The following is a description of a gene set: Genes predicted to be targets of miRBase v22 microRNA hsa-miR-5706 in miRDB v6.0 with MirTarget v4 prediction scores > 80 (high confidence targets). Human Gene Set: MIR5706 studied in species Homo sapiens from publication Chen Y, Wang X (PMID 31504780), and this is the list of marker genes: PATE4, RAD23B, GXYLT1, RBFOX1, IGF2BP3, RFC3, GCOM1, RPS6KA5, PGM2, RHAG, AZIN1, ALX4, RYR3, CXCL8, ABCC9, CTCF, ALAS1, ZCCHC7, PRRX1, WDR48, PRKG2, LHX9, CD302, RBM18, SLC2A5, TRMT11, CHL1, GYS1, MIER1, TMEM212, PTGER3, LY75-CD302, KCNAB1, ANKRD17, VTI1A, NFIB, CSPG5, PSMB4, SHISA6, CDK6, TMEM135, ZNF749, SPOP, PNPLA4, UNC5C, ALDH9A1, ADAM29, OSTC, DDAH1, CLEC19A, CHST9, STRIP1, DNMT3A, SASH1, DERL2, TMTC4, RHOQ, TMEM255A, FNBP1, NFAT5, ACER3, IFI6, HIGD1A, DCUN1D3, PCDH9, TMOD2, CAPN12, KCNMA1 (NCBI Gene Id 3778), DDI2, SAMD12, GFOD1, MAGI3, EMC7, NAA25, SOX6, CALN1, UBE2W, CRIPT, VSX1 (visual system homeobox 1), GRIA2, ARHGEF12, CNOT2, GPATCH11, HOXC10, CD28, UBXN10, CPEB2, CD164, PTGER4, FIGN, CFLAR, FAM180A, SAMD9, UNC5B, PLEKHA5, CEP44, FBXL17, TCTN1, BAZ2B, CACNA1E, MAT2B, STAG2, MIER3, CEP192, SUMO2, RNF6, CERKL, RPS6KA2, VEGFA, PAG1, TBC1D8B, ADGRE2, LYPD1, TM9SF3, GPR3, P2RX7, TSPAN33, POGZ, CCDC122, HIPK4, SMPD3, ZMAT4, PAK5, NAB1, CAST, ELOVL3, KRBOX4 (NCBI Gene Id 55634), KLHL12, MID1IP1, PGRMC1, DYNC1LI2, CTNNA3, DENND1B, CXXC4, PEG10, TLN2, TAF1B, FER, TBX18 (T-box transcription factor 18, NCBI Gene Id 9096), PKDCC, MTO1, ZFP1, CTAGE1, SYT9, SLC26A9, NCBP1, ATXN1, TOX3, GET1-SH3BGR, MYRIP, ZNF534, LNPEP, CUX2, SH3BGR, TENM1, WDR26, SOAT1, ATP6V0C, GPR107, VSIG1, ADD3, GALNT15, C15orf40